The following is a description of a gene set: from publication Haslinger C, Schweifer N, Stilgenbauer S, Döhner H, Lichter P, Kraut N, Stratowa C, Abseher R (PMID 15459216) Human Gene Set: HASLINGER_B_CLL_WITH_CHROMOSOME_12_TRISOMY studied in species Homo sapiens Genes changed in the B cell chronic lymphocytic leukemia (B-CLL) with trisomy of chromosome 12. PURPOSE: Genomic aberrations and mutational status of the immunoglobulin variable heavy chain (VH) gene have been shown to be among the most important predictors for outcome in patients with B-cell chronic lymphocytic leukemia (B-CLL). In this study, we report on differential gene expression patterns that are characteristic for genetically defined B-CLL subtypes. MATERIALS AND METHODS: One hundred genetically well-characterized B-CLL samples, together with 11 healthy control samples, were analyzed using oligonucleotide arrays, which test for the expression of some 12,000 human genes. RESULTS: Aiming at microarray-based subclassification, class predictors were constructed using sets of differentially expressed genes, which yielded in zero or low misclassification rates. Furthermore, a significant number of the differentially expressed genes clustered in chromosomal regions affected by the respective genomic losses/gains. Deletions affecting chromosome bands 11q22-q23 and 17p13 led to a reduced expression of the corresponding genes, such as ATM and p53, while trisomy 12 resulted in the upregulation of genes mapping to chromosome arm 12q. Using an unsupervised analysis algorithm, expression profiling allowed partitioning into predominantly VH-mutated versus unmutated patient groups; however, association of the expression profile with the VH mutational status could only be detected in male patients. CONCLUSION: The finding that the most significantly differentially expressed genes are located in the corresponding aberrant chromosomal regions indicates that a gene dosage effect may exert a pathogenic role in B-CLL. The significant difference in the partitioning of male and female B-CLL samples suggests that the genomic signature for the VH mutational status might be sex-related., and this is the list of marker genes: MCRS1, MTCP1, PMF1, NCKAP1L, MYF6, TIMELESS, SRSF9, JCHAIN, RRAGA, PWP1, M6PR, GLIPR1, ATP2B1, DYRK2, WASHC4, SNRPF, ANKLE2, MLXIP, GIT2, ANAPC5, ARPC3, VCL, HIP1R